The following is a description of a gene set: The multiplication or reproduction of endothelial cells, resulting in the expansion of a cell population. Endothelial cells are thin flattened cells which line the inside surfaces of body cavities, blood vessels, and lymph vessels, making up the endothelium. Human Gene Set: GOBP_ENDOTHELIAL_CELL_PROLIFERATION studied in species Homo sapiens, and this is the list of marker genes: APLNR, MIR34A (microRNA 34a), HMOX1, MIR23A, PRKD1, IGF2, MIR150, MIR495, ITGB1BP1, MYDGF, MIR193A, MIR483, AIMP1, PDCD10 (NCBI Gene Id 9226), PTPRM, APOA1, NRP1 (neuropilin 1), PDGFB, SIRT6, MIR10B, EGFL7, NUS1, PIK3CD, MIR15B, MIR342 (NCBI Gene Id 442909), MIR10A, RGCC, THAP1, CXCR3, CXCL12, DLG1, MDK, PRL, MIR361, PDCD6, FGFR1, FGFBP1, FLT1, SIRT1, STAT5A, HSPG2, MIR129-1, COL4A3, NRP2, MIR146A, STAT1, SPARC, MIR2355, ENG, CCL11, XBP1, MIR30B, BMP4, SYNJ2BP, MEF2C, APOE, FLT4, MIR503, PDPK1, MIR30E, TNF, LRG1, F3, CDH13, LIPA, MIR98, MIR24-1, PRKD2, CAV1, MIR487B, VASH2, NRAS, APLN, MIR424, STAT3, EMC10, MIR410, VEGFB, THBS1, NRARP, TGFBR1, MIR20B, FGF7, SEMA5A, IL12B, KDR, KRIT1, MIR92A1, MIR499A (NCBI Gene Id 574501), BMPR2, MIR205, TNMD, MIR494, ACVRL1, FGF16, COL8A2, MIR22, WNT5A, MIR29A, LOXL2, GATA2, ANG, TEK, MMRN2, PROX1, ADAM17, BMP6, NR2F2, SULF1, VSTM4, DLL4, SP1, SLC39A9, TIE1, IL12A, CCL24, GHSR, FGF18, MIR497, ANGPT1, MIR135B, JUN, PPP1R16B, MMP14, MIR26A1, CALCA, MIR329-1, ATP5F1A, JCAD, RPTOR (NCBI Gene Id 654218), MIR15A, ECM1, NF1, GDF2, SCG2, HTR2B, ANGPT4, LEP, MIR130A, PRKX, POLD4, ATP5IF1, HMGB1, EPHA2, MIR27A, PRKCA, ITGB3, ITGA4, MIR16-1, IL10, SCARB1, PLXNB3, APOH, MIR200C, CCL2, AGTR1, BMPER, MIR149, COL8A1, VEGFA, FGF2, EGF, MIR101-1, PLCG1, AKT3, NOX5, HIF1A, CAV2, MIR21, GHRL, PROK2, MIR133B, ALDH1A2, MIRLET7B, CCR3, THBS4, CCL26, PROK1, DBH (NCBI Gene Id 1621), ATOH8 (NCBI Gene Id 84913), ARNT, FUT1, MIR29C, FGF10, CNMD, ZNF580, MIR222, MIR27B, NR4A1, AGGF1, EGR3, RICTOR, HMGB2, ALOX5, MIR492, FUT2, AKT1, ERN1, TNFSF12, VASH1, PPARG, PIK3CB, CYBA, ZEB2, PDCL3, MIR152, CD34, MIR132, MIR126, NGFR, APELA